The following is a description of a gene set: studied in species Homo sapiens Abnormal myocardium morphology Human Gene Set: HP_ABNORMAL_MYOCARDIUM_MORPHOLOGY A structural anomaly of the muscle layer of the heart wall., and this is the list of marker genes: POLG2, CALM2, PGM1, GET3, MAP2K2, IDS, CISD2, MT-TV, TTR, SGCA, SPTB, WARS2, TOP3A, MT-ND5, UQCRFS1, DLK1 (delta like non-canonical Notch ligand 1), PPA2, TPM2 (NCBI Gene Id 7169), COA8, TTPA, MYOCD, RNASEH2B, RRAGD, GNE, NDUFB7, SDCCAG8, SHMT2, MYZAP, VEZF1, SCO2, JAG2, DOLK, HSPG2, WFS1, CHKB (choline kinase beta), OPA1, RAB3GAP2, FHOD3, MT-TS2, EMD, SYNE1, PMM2, ECHS1, KRAS, SLC2A10, CACNA1A, PKP2, TNNC1, YARS2, METTL27, NNT, SDHD, WDPCP, TKFC, ATP6V1A, MRPS14, CAP2, MC2R, RPS6KA3, BRAF, RBM20 (NCBI Gene Id 282996), PHYH, ARL6, MYH7, XRCC4, IFT27, NEK8, BBS4, RMRP, GUSB, HJV, COX14, MYL3, LAMA4, SCAPER, MICU1, LRPPRC (leucine rich pentatricopeptide repeat containing), NDUFAF8, FNIP1, FANCB, INSR, POMT2, ERCC6, JUP (NCBI Gene Id 3728), SPEN, ERCC8, FAH, MT-ATP8, TWNK, MT-ND2, KBTBD13 (kelch repeat and BTB domain containing 13), ATAD3A, RNASEH2C, GMPPB, GLA, RPL3L, FANCE, FASTKD2, NONO, NDUFA2, MRAP, DHX9 (DExH-box helicase 9), GNPTAB (NCBI Gene Id 79158), GNS, HNRNPA1, TRIM37, GTF2IRD1, RNU4ATAC, B2M, MYH6, SLC40A1 (solute carrier family 40 member 1), IDUA, PEX5, TNNT2, HADHB, AGK, PNPLA2, TGFB1, SLC19A2, RYR2, FLNC, IFT74, PRKCZ, LIMK1, RNF113A, CEP290, TANGO2, BBS1, ERCC4, VARS2, LUZP1, SPRED2, MMUT, SRP54, HAMP, SLC1A3, SMC1A, TRNT1, SPEG, MYOZ2, RNASEH2A, RMND1, TMEM126A, SUFU, KANSL1, SGSH, CBL, NDUFS6, PPCS, CLN3, ADSS1, MT-TT, XRCC2, COX15, TXNRD2, FBXL4, HSD17B10, PEX16, ATP1A3, BMP2, MT-TW, ATP5MK (ATP synthase membrane subunit k), LMNA, NDUFS8, PEX7, MT-TN, COQ4, KLHL41, ERBB3, SBDS, BBS12, LAMB3, MRPL39, ATP5F1E, HMGCL, GATAD1, BAZ1B, GTF2E2, MYSM1 (Myb like, SWIRM and MPN domains 1), TPI1, PEX3, MLYCD, MICOS13, PDPN, COX7B, DEF6, BUD23, KCNJ8, AIP, CRYAB, TLR4, GYG1, ABCC6, D2HGDH, IKZF1, CYP2R1, KLRC4, KCNH1, IGF2, BCS1L, BRCA1, CCR1, VCP, SQSTM1, UBR1, MRPS22, CPT1A (carnitine palmitoyltransferase 1A), ANKRD1, TNNI3K, FIG4, ALPK3, NDUFA6, DDX3X, GAA, FTO, FANCI, EYA4, TFR2, MAD2L2, GYS1, TNFRSF1A, ANK1, NAGLU, PEX10, AGL, GBE1, SLC4A1, AARS2, MYO18B, EIF4H, TULP3, RBCK1, HBB, PRDM16 (NCBI Gene Id 647868), FLNA, DSP, ACTN2, SCLT1, ARSB, NDUFS1, COX10, DMD, NDUFA11, APOA1, RTL1, TRMT5, CAVIN1 (caveolae associated protein 1), NPPA (natriuretic peptide A), MT-ND6, BOLA3, KCNJ11, NDUFA1, VHL, PYGL, MT-ND4, ADAR, IL12A (interleukin 12A), CPT2, TTC8, COX6B1, ERCC2 (NCBI Gene Id 7269), PPP1R13L, ALG3, MCM10, XYLT1, TRDN, RERE, MT-TK, KAT6B, FHL1, DCAF8, RRAS, COA5, PARS2, NDUFAF2, PYGM, MLX, MYBPC3 (myosin binding protein C3), NDUFS4, RAF1, ACAD8, CFAP418, FAS, SURF1, PPP1CB, LSM11, VPS37D, GPR101, TAFAZZIN, POMK, QRSL1, ADA2, MT-TF, RASA2, SCN5A, XYLT2, LIMS2, IDH2, ACADS (NCBI Gene Id 35), MT-CO3, MEG3, MEFV, BMP6, ALG1, MKKS, VPS13A, TNNI3, GTF2IRD2, FANCD2, DPM3, LETM1, ATP5F1A, FANCM, PCCB, TGFB3, FOXRED1, HADHA, VCL, FKRP, MMACHC (metabolism of cobalamin associated C), MRPL3, HRAS, TAF1A, GTF2H5, NF1, UBE4B, BAG3, SUCLG1, SLC6A6, BRCA2, LIAS, SGCB, SLX4, GJA5, FXN, ERAP1, ENPP1, BBS2 (NCBI Gene Id 583), DTNA (dystrobrevin alpha), FANCF, JPH2, NDUFAF4, TBX5, MYOT, MT-ND1, CALM1, BRIP1, AHCY, CSRP3, NDUFB10, ERCC3, PEX12, FLII, HFE, LZTR1, HCCS, TIMMDC1, MT-TH, LDB3, KLHL24, SAA1, CLPB, MPLKIP, C1QBP, ABCC9, KLF1, DES, POLG, STAR, MYL2, ADORA2A, PHKG2, TCAP, TSFM, ADCY5, UBE2T, MIB1, IL23R, PRUNE1, FHL2, USP9X, TBL2, ANKRD11, IL10, TREX1, TRIP4, DLD, TTN, TPM3, BAG5, PEX14, NDUFV2, HADH, UCP2, MT-ND3, SNUPN, NAGA, NDUFAF1, KCNAB2, CASZ1, ACTC1, LZTFL1, CNBP, MTO1, PPARG, TMEM43, GABRD, CRLS1, DSC2 (NCBI Gene Id 1824), RNF220, ATP1A2, NEXN, CLIP2, MGME1, ACAD9 (acyl-CoA dehydrogenase family member 9), RNU7-1, KIF20A, HNRNPA2B1, GATA4, AARS1, PEX2, BBIP1, LAMA2, IFNGR1, LAMC2, HAND2, SLC5A6, NDUFB3, BBS9, IL12B (NCBI Gene Id 7907), GPC3, NRAS, SLC25A20, IRF4, SDHB, FANCL, C4A, GTPBP3, MIPEP, SLC22A5, SLC25A4, SLC25A3, NEB, FKBP6, ABHD5, PEX11B, TPM1, DNAJC30, CCND1, SAMHD1, MMAB, GBA1, IFIH1, TMEM70, PPP1R21, GTF2I, TK2, SDHA, XK, ATP5F1D, PEX1, MT-TQ, SHOC2, VAC14, THBS2, COQ2, NEU1, NUP107, RRAS2, MRAS, MT-CO1, UBE3C, DNAJB4, RIT1, NDUFA10, IL12A-AS1, TARS1, TMPO, PTPN11, LTBP4 (latent transforming growth factor beta binding protein 4), SERPINE1, EPG5, ANO5, NDUFAF5, ITPA, STX1A, PIGT, MT-ATP6, ANKS6, TERT, PEX13, MRPL44, CAPNS1, PLN, BBS7, LMOD2, SYNE2, SPTA1, GATC, NFS1, ELAC2, VPS33A, RFC2, PSEN2, PSEN1, MMP23B, GLB1, DSG2, KCNQ1, LRP12 (LDL receptor related protein 12), COA6, BBS10, DHCR7, NBAS, HPS1, HCN4, MYLK2, POMGNT1, DNAJC19, RRAGC, FOS, SGCD, CEP19, IFT172, KCNJ2, MEN1, NDUFS7, ACTA1, MT-CO2, GATA5, POMT1, PALB2, DNAJC21, FANCG, GPC4, SOS2, KCNQ1OT1, MT-TL1, MMP1, PDGFRA, TMEM270, CASQ2 (NCBI Gene Id 845), RNASEH1, GSN, BRCC3, EPB42, RFWD3, SMPX, HGSNAT, MKS1, RRM2B, PEX19, TRIM32, LAMA3, SDHAF1 (succinate dehydrogenase complex assembly factor 1), NCF1, BBS5, ACADVL, NDUFS3, CDKN1C, ALMS1, FANCC, LAMP2, STAT4, NDUFV1, NDUFAF3, ELN, CENPE, FKTN, COL7A1, PCCA, MYPN, GNAI2, RAD51, NUBPL, CYP27B1, RAD51C, AGPAT2, PEX6, TNNT1, SARDH, CAV3, FLAD1, GPX4, ABCC8, KCNJ5, FANCA, ATPAF2 (ATP synthase mitochondrial F1 complex assembly factor 2), SKI, MAP2K1, CARS1, UBAC2 (NCBI Gene Id 94902), CAV1, NDUFS2, NAXD, NDUFB9, NPHP1, TIA1, TAPT1, SLC30A10, SOS1, TMEM126B, PRKAG2, HLA-B, BSCL2, PHKA2, PEX26, PTPN6, NDUFB11